Given this list of marker genes AP3D1, KIT, BLOC1S5, ENPP1, OR51E2, GNA11, AP1M1, MITF, RAB27A, KITLG, ZEB2, ADAMTS20, BLOC1S3, ADAMTSL4, ANKRD27, USP13, BLOC1S6, CITED1, RAB32, CD63, SOD2, LRMDA, TYRP1, EDNRB, EDN3, ADAMTS9, RAB38, MREG, GLI3, SOX10, HPS4, BCL2 (NCBI Gene Id 596), MEF2C, AP1G1, OCA2, here is a description of the gene set: The process in which a relatively unspecialized cell acquires the specialized features of a pigmented cell, such as a melanocyte. species: Homo sapiens Human Gene Set: GOBP_PIGMENT_CELL_DIFFERENTIATION